Given this list of marker genes Nrp1, Msn, Egf, Nf2, Egfr (epidermal growth factor receptor), Arl8b, Sorl1, Rdx, Vegfa, Mgat3, Ezr, Dtx3l, Rock2, here is a description of the gene set: Mouse Gene Set: GOBP_PROTEIN_LOCALIZATION_TO_EARLY_ENDOSOME A process in which a protein is transported to, or maintained in, a location within an early endosome. studied in species Mus musculus